Given this list of marker genes ALPL, MN1, SPP1, PIM1, SFRP1, KL, STC2, VDR, RXRA, FES, PTH, CDKN2D, MED1 (mediator complex subunit 1), TRIM24 (tripartite motif containing 24), NCOA3, MIR125B1, CASR, BMP7, STC1, PENK, TGFB1, AQP3, TRIM25, KANK2, TYR, PHEX, BGLAP, CXCL10, ABCB1, GDAP1 (ganglioside induced differentiation associated protein 1), GPRIN3, TPCN2, FGF23, CYP27B1, CD4, SNW1, TNC, SNAI2, CYP24A1, RXRB, here is a description of the gene set: Human Gene Set: GOBP_RESPONSE_TO_VITAMIN_D Any process that results in a change in state or activity of a cell or an organism (in terms of movement, secretion, enzyme production, gene expression, etc.) as a result of a vitamin D stimulus. studied in species Homo sapiens